The following is a description of a gene set: Reproduction Mouse Gene Set: REACTOME_REPRODUCTION species: Mus musculus, and this is the list of marker genes: Cd9, Catsperd, Adam21, Ovgp1, Adam2, Catsper3, Adam30, Dmc1, Acr, Hvcn1, B4galt1, Izumo4, Izumo2, Zp1, Fignl1, Zp2, Izumo1, Kcnu1, Rad51, Hyal5, Adam25, Catsper4, Catsperb, Zp3, Izumo3, Catsper1, Firrm (FIGNL1 interacting regulator of recombination and mitosis), Catsperg1, Catsper2